Given this list of marker genes ATR, PLAAT3, AKAP8L, CDK1, DCTN1 (dynactin subunit 1), PAFAH1B1, PRKCB, VRK1, NEK6, LPIN1, PRKCA, CTDNEP1, PLK1, here is a description of the gene set: The controlled breakdown of any cell membrane in the context of a normal process such as autophagy. studied in species Homo sapiens Human Gene Set: GOBP_MEMBRANE_DISASSEMBLY